The following is a description of a gene set: Mouse Gene Set: REACTOME_REGULATION_OF_BACH1_ACTIVITY studied in species Mus musculus Regulation of BACH1 activity, and this is the list of marker genes: Mafk, Ubc (NCBI Gene Id 77003), Bach1, Rps27a, Uba52, Fbxl17, Skp2, Rbx1, Uba52rt, Ubb, Cul1, Skp1